The following is a description of a gene set: studied in species Homo sapiens Human Gene Set: GOBP_CALCIUM_ION_TRANSPORT The directed movement of calcium (Ca) ions into, out of or within a cell, or between cells, by means of some agent such as a transporter or pore., and this is the list of marker genes: TRPM1, CDK5, NALF1, ANO6, CHRNA9, NOL3, F2RL3, TMC1, HRC, CYP27B1, GPR35, FFAR1, STIMATE, FLNA, STAC3, GRINA, CACNA1A, UBQLN1, HTR2C, TRPV4, HAP1, SEC61A1, PIK3CG, MYLK, JPH2, PRKD1, SCN11A, PKD1L3, STRIT1, PSEN2, GCK, TRPC4AP, CACNA1C, SLC8B1, PKD2L1, RGS4, P2RX1, MIR21, KCNK16, CATSPER3, ANXA6, STIM2, CCL5, CYSLTR1, GPM6A (glycoprotein M6A), TPCN1, SLC24A3, ANO9, PML, BEST1, GRIN2C, FKBP1B, GRIN3A (NCBI Gene Id 138370), ATP2A2, ATP2A3, PLCH2, PACSIN3, CATSPER4, CNGA3, TRPM6, CD84, JPH3, PLCB1, INPP5K, TMBIM6, MIR1-1, YWHAE, SNCA, STAC2, NOS1, PPP3CC, GRIN2D, GRXCR1 (glutaredoxin and cysteine rich domain containing 1), ANK2, LETM2, CNGA2, BSPRY, ADCYAP1R1, PDE4B (phosphodiesterase 4B), NCS1, TRPM3, UCP2 (NCBI Gene Id 7351), TRPM4, FYN, NGF, ISL1 (ISL LIM homeobox 1), CTNNB1, ATG5, HSPA9, G6PD, TMEM37, ORAI3, CUL5, PLCZ1, TRPV6, SELENON, APLNR, TRPC6, PKD2L2, TPT1, GP1BA, SLC35G1, DHRS7C, CACNG6, DNM1L, SESTD1, NOS1AP, UBR3, ATP1A2, KCNJ8, BIN1, SLC24A1, GRIN2A, CACNA1D, CASR, LYN, AHNAK, EDN1, GRIN2B, CLCA1, PKDREJ, MYB, GP1BB, NTSR1, PLCL1, PLCH1, ERO1A, CHRNA7, CACHD1, SUMO1, PKD1, TRPM2, CACNG2, CACNA2D1, CASQ1, CEMIP, ABL1, KCNN4, IL13, LGALS3, CAV3, TGFB1, CCL8, MCHR1, TRPC1, LILRA2 (NCBI Gene Id 11027), CACNA1G, TRPC3, CATSPER2, SLC8A3, ITPR3, CACNA1I, IL16, TRPV1, TSPAN13, TRPV2 (NCBI Gene Id 51393), CACNG5, MIR208B, MIR200C, CACNA2D2, MCUB, GP9, TMBIM1, CREB3, MCOLN1, PDGFRB (platelet derived growth factor receptor beta), P2RY6, GPER1, EFHB, TRPM7, JPH4, SLC25A25, BAK1, DMD, DDIT3, ITGB3, P2RX6, CACNB1, P2RX3, AKAP6, RYR1 (NCBI Gene Id 906), CNGB1, RAMP2, PANX3, STIM1, ITPR2, CACNG3, PKD1L2, HTT, PLPP4, LILRB1, ATP2C2, GSTO1, SPG11, CACNA1B, CALHM3, GNB5 (G protein subunit beta 5), XCL1, SLN, PLCG1, CD19, PRKCB, SLC3A2, CCL19, PANX1, STAC, CACNG4, CACNA2D3, CATSPER1 (cation channel sperm associated 1), HPCA, MCU, CACNA1H, TRDN (triadin), NPPA, CACNG7, FCRL3, PPP3CA, LILRB2, PMPCB, TSPO, RAMP3, MS4A1, CAV1, HTR2B (5-hydroxytryptamine receptor 2B), ORAI2, FMR1, CACNB4, TRPA1, F2R, RYR2, TRPC5, CAMK2G, SLC24A4, CACNA2D4, CCL21, SARAF, HOMER2, SPINK1 (serine peptidase inhibitor Kazal type 1), CACNA1F, TRIM27, ITPR1, NPSR1, EPM2A, EPB41, MAIP1, GRIN1, CSN2, FKBP1A, MIR208A, BDKRB1, SLC8A1, PLCE1, MIR499A, P2RX4, TRPC7, MCOLN2, THY1 (Thy-1 cell surface antigen), TMEM38A, SLC24A2, APP (amyloid beta precursor protein), UBASH3B, PKD1L1, CHD7, PPP3CB, MCOLN3, CD4, PRKACA, RCVRN, TMX1, GSTM2, CHRNB2, NOS3, MICU1, CACNB3, EDNRB, EPO, MIR424, TMBIM4, LETM1, CCR7, ATP2B4, AFG3L2, HTR2A, CXCL11, P2RX5, TRPM8, CYBA, SELENOK, PLCB4, CRH, GNAI2, PTPN6, PPP3R1, LIME1, CCL2, CRACR2B, ORAI1, CALCRL, MIR133A1, TLR9, CX3CL1, GP5, P2RX7, EPPIN, STC1, SLC25A23, MIR328, PRNP, CAMK2D, CALCA, PTK2B, CNGA1, GRAMD2A, PLCL2, ATP1B1, FASLG, FGF2, PDE4D, PLCG2, HOMER1 (NCBI Gene Id 9456), MCUR1, TPCN2, CALM3, CASK (NCBI Gene Id 8573), TMCO1, LCK, CHRNA10, ADORA2A, TRPV3, OPRD1 (NCBI Gene Id 4985), MIR34A, WNT3A, CNGA4, STC2, PRKCE, PKD2, CXCL12, PLN, PDPK1, MICU3, GRM6, TMC2, HCRT, SLC24A5, PLCB2, CRACR2A, LACRT, CACNG8, CXCR3, ADRA2A, ATP2B3, CACNB2, EGF, CAMK2A, SLC30A1, DRD1, VDAC1, CALHM2, PLCB3, CCL3, CHRNA4, CAPN3 (calpain 3), PPP3R2, PDGFB, CCR1, HES1, TMEM38B, METTL21C, CBARP, CACNG1, ATP2B2, BAX, SPG7, OPRM1, CDH23, SRI, PSEN1, GCG, DRD2, TOR2A, TRPC4, UCN, FAIM2, AKAP5, NALF2, CRHR1, CALM1, CALHM1, ITPRIPL1, DIAPH1, WFS1, GAS6 (NCBI Gene Id 2621), MRLN, MICU2, ATP2C1, CALM2, TRPM5, ATP2B1, CHERP (NCBI Gene Id 10523), RYR3, SLC8A2, CORO1A, TRPV5, VDR, ASPH, WNK3, PTPRC, CASQ2, CAMK2B, MIR93, PLA2G1B, CCR5, GHITM, CCL4, CXCL9, NIPSNAP2, ASIC1, LPAR3, ITGAV, HOMER3, CACNA1E, BHLHA15, TMEM165, P2RX2, ZMPSTE24, IBTK, VMP1, EDNRA, RAMP1, CACNA1S, SMDT1, NALCN, CXCL10, REM1, GRIN3B, JPH1, RGS9, XCR1, SRL, ATP2A1, F2, CLIC2, LILRA5, BCL2, SEMG1